Given this list of marker genes NCAPD3, NCAPD2 (non-SMC condensin I complex subunit D2), NCAPH2, SMC4, SMC2, NCAPH, here is a description of the gene set: Compaction of chromatin structure prior to meiosis in eukaryotic cells. species: Homo sapiens Human Gene Set: GOBP_MEIOTIC_CHROMOSOME_CONDENSATION